The following is a description of a gene set: from publication Lázaro S, Pérez-Crespo M, Lorz C, Bernardini A, Oteo M, Enguita AB, Romero E, Hernández P, Tomás L, Morcillo MÁ, Paramio JM, Santos M (PMID 31611390) species: Mus musculus Rb1<F/F>; Rbl1<-/->; Pten<F/F>; Trp53<F/F> mice were generated by breeding Trp53<F/F>; Pten<F/F> mice with Rb1<F/F>, Rbl1<-/-> mice. Genes differentially regulated in CMV-QKO LCNEC tumors from Rb1<F/F>;Rbl1<-/->;Pten<F/F>;Trp53<F/F> mice versus normal lung tissue. Mouse Gene Set: LAZARO_GENETIC_MOUSE_MODEL_HIGH_GRADE_LARGE_CELL_NEUROENDOCRINE_LUNG_CARCINOMA_DN, and this is the list of marker genes: Thbd, Nat8f7, Ctla2a, Abca5, Cd79a, Grap, Cmklr1, Nr2f2, Crim1, Zfp953, Hspa12b, Ngp, Ahnak, Popdc2, Raver2, Etv5, Cd226, Smad7, Rasip1, 4933412E12Rik, Arhgef15, Klhl5, Spata31f1a, Des, Gpm6a, Fmo5, Map3k20, Dpysl2, Slc16a9, Lyz1, Aox3 (aldehyde oxidase 3), Pcolce2, Zkscan3 (zinc finger with KRAB and SCAN domains 3), Prx, Cyyr1, Pals1, Itk (IL2 inducible T cell kinase), S1pr1, Fcmr, Ptprb, Gm23792, Tmod1, Map4k1, Sh2d1b1, Pxdc1, Gata2, S100a13, Trbj1-1, Wnt2, Cep85l, Arl15, Adgre4, Gimap5, Ankrd44, Nipal3, Hyal1 (hyaluronoglucosaminidase 1), Adra1a, Gas6, Klf2, Rras, Zfp982, Lef1, Lims2, Napsa, Gm14412, Slamf1, Dennd5b, Reck, Tmem140, Arhgap6, Adamts8, Vsnl1, Popdc3, Adrb1, Map4k2, Chpt1, Tbx5, Scn7a, Fgd5, Kif13a, Amph, Ackr2, Fgf7, Gm26404, Foxf2, Sox18, Il16, Prodh, Sod3, Acap1, Cd3g, Il17rd, Hecw2, Tmem71, Icam2, She, Dusp7, Ehd4, Cyp2j9, Tspan18, Prickle2, Rspo1, Ndrg2, Ar, Gm9917, Zbtb4, Grap2, Gm3364, Slc24a4, Phactr2, Dusp3, Ikzf3, Upk1b (uroplakin 1B), Akap5, Upk3b, Olfml1, Ppp1r3c, Clec1a, Trib2, Chrnb1, Shroom4, Hilpda, Scel, Dgka, Tbx4 (NCBI Gene Id 237907), Sema3g, Ccl19-ps2, Tnxb, Slc6a4, Ets1, 2010310C07Rik, Cavin2 (caveolae associated 2), Clic5, Ifi205 (NCBI Gene Id 226695), Scnn1g, Tie1, Mypopos, Fhl1, Mmrn1, Ppp1r14a, Npr3, Prex2, Gsn, Ramp2, Epas1, Fabp1, Trbj2-1, Abca6, Cd300e, Prf1, Tmt1a3, Pakap, Phldb2, Dmd, Gria1 (glutamate receptor, ionotropic, AMPA1 (alpha 1)), Nod1, Ripor2, Impdh1, Slc22a3, Tas2r143, Serpina3c, Rtkn2, BC028528, Plpp3, Trappc9, Hsd11b1, Rgs18, Smad6, Gm17473, Sgip1, Tespa1 (NCBI Gene Id 67596), Nox4, Myh11, Prdm6, Tecrl, Lipg, Zfp697, Fchsd2, P2ry10, Glp1r, Myzap, Mustn1, Cd8a (CD8 subunit alpha), Ids, Matn4, Numb, Gm25831, Gm23258, Icam1, Cldn5, Dll4, Ripor1 (NCBI Gene Id 75687), Ms4a4b, Aff3, Slc13a4, Gab3, Myl9, Ablim3, Tmem204, Tmem44, Nrn1, Lbh, Rasgef1a, Stap1, Pdlim3, Pax5, Angpt1, Muc16, Cnr2, Myadm, Fermt2, Adam4, Arhgef26, Fam13c, Gm336, Igfbp6, Dpp4, Stmn2, Gm10824, Pde9a, Kank4, 2410004I01Rik, Serpinb10, Fam184a, Ros1, Fgfr4, Nxpe3 (NCBI Gene Id 385658), Ttc7b, Prelp, Ccm2l, Cd19, Bex4, Mxra7, Scgb1c1, Tns1, Kit, Meis1, St8sia4 (ST8 alpha-N-acetyl-neuraminide alpha-2,8-sialyltransferase 4), Erg (ETS transcription factor), Cspg4b, Gm22520, Chrdl1, Plscr4, Tmt1a, Dennd5a, Prdm8, Adamtsl5, Tnfsf15 (NCBI Gene Id 326623), Rarres2, Flvcr2, Stard13 (NCBI Gene Id 243362), Arhgap15, Hmbox1, Krt79, Acoxl, Hdac7, Slc1a3, Tppp, Pde5a, Cbfa2t3, Abca17, H2-T24 (histocompatibility 2, T region locus 24), Plscr2, Sptbn1, Gbp4, Txk, Pdk2, Adgrf5, Gucy1a2, Mmd, Fam162b, Lmntd1, Actc1, Sult1a1, Ushbp1, Gpr18 (G protein-coupled receptor 18), Cyp2d22, Ager, Vegfd, Sh3bp5, Arhgap29, Cav2, Sh3tc2, Cytl1, Ccr7, Acvrl1 (NCBI Gene Id 11482), 4933409K07Rik, Kmo, Gap43, Kcna3, Gp9, Galnt18, Rasgrp2, Bmp6, Plac9, Trbd1, Fgf1, Cyp4b1, Aass, Ppm1f, Slc43a3, 6530402F18Rik, BE692007, Ace, Arap3 (ArfGAP with RhoGAP domain, ankyrin repeat and PH domain 3), Hyal2, Prkcq, Ccn5, Foxf1, Syne1, Otud1, Tns2, Prkg2, Heg1, Dhdh, Ntng2, Cryab, Mturn, Prickle1, mt-Co3, Lrat, Elovl1, 2610027K06Rik, Clec14a, Myct1, Zfp708, Grem2, Robo4, Trbj1-4, Nckap5, Traj18, Crispld2, Rgs6, Cdc42ep1, Hykk, Adgre5, 9530026P05Rik, Tmem234, Cd40, Afap1l1, Lats2, Lyve1, Mir145a, Kdr, Sema6a, Efnb2, Snord61, Mcc (mutated in colorectal cancers), Krt80, Clec9a, Themis, Grk5, Il27ra, Cd8b1, Bank1, Bmpr2, Gimap8, Sstr4, Mir28c, Higd1b, Pgm5, Ltbp4, Npr1 (NCBI Gene Id 99760), Tbx3os1, Kank3, Pcdh1, Gm11651, Macf1, H6pd, Nkg7, Scube2, Hbb-bs, Amigo2, Tek, Sox17, Lpcat1, Wwc2, Zfp641, Abca8b, Mtmr10, Vipr2, Cemip2, Pdzd2, Ctla2b, Spata31f1b, Tmcc2, Thsd1, Kitl, Calhm5, Dach1, Atp1a2, Egfl7, Ston1, Ppp1r16b, Mettl24, Flt3l, Lrrn3, Fendrr, Prkd2, Hspb1, Lgi3, Gm26236, Ankrd1, Tmem100, Ccdc85a, Samd12, Traj9, Gja4, C1qtnf2 (C1q and tumor necrosis factor related protein 2), Acot1, Rmdn2, Tcf21, Fam107a, Shank3, Pitpnc1, Cyp27a1, Fmo3, B130024G19Rik, Col4a3, Ciita, Sox7, Ppbp, Adk, Flt1 (NCBI Gene Id 14254), Gpr182, Wdfy4, St6galnac3, Maoa, Gcsam, Hopx, Adamtsl4, Npnt, Car14, Efcc1, Gzma, Hoxa5, Asap2, Stard9, Zfp975, Platr22, Tagln, Slc6a2, Gdpd3, Cnn1 (NCBI Gene Id 12797), 6430548M08Rik, Prr5l (NCBI Gene Id 74608), Scnn1b, Tbx3, Rapgef3 (Rap guanine nucleotide exchange factor (GEF) 3), Arhgef18, Itga8, Ppp1r14c, Klrd1 (NCBI Gene Id 16643), Edn1, Car4, Nipa1, Mapt, Bvht, Csgalnact1, Tspan7, Gm24620, Gimap1, Gpr141b, Rasal3, Rtp3, Pced1b, Zfp366, Gm23101, Gimap3, Adcy8, Clba1, Cdkl5, Nkain4, Traf3ip3, Pdgfb, Slc7a10, Hhip, mt-Ta, Notch4, Slc5a12, Chst3, Rhob, Itgb7, Dock9, Xdh (xanthine dehydrogenase), Aldh1a1, Tmcc3, Synpo2, Stard8, Parvb, Synm, mt-Tq, Mill2, Akap12, Plxna1 (plexin A1), Reps2, Plvap, Nherf2, Serpinb9, Ms4a1, Pkhd1l1, Mirlet7a-1, Hdx, Traj22, Cd27, Dock4, Kctd21, Fcrl1, Fam174b, Gpr33, Tacc1, Mmrn2, Gm10400, Cyria, Gucy1b1, Cd209a, Gm10287, Cd2, Slc39a8, Esam